Given this list of marker genes RB1, EGFR, IL6, ELK1, FAS, HSP90AA1, TRAF6, JUN, CCNE1, IL2, IFNG, FASLG, MAPK11 (mitogen-activated protein kinase 11), JUNB, HBEGF, FOS, MAP2K6, BCL2, ADAMTSL4-AS1, BCL3, NFE2L2, CDKN1A, BAK1, MAPK8, TNFSF10, CCNA2, TNFRSF1A, CFLAR, TP53, MMP2, TNF, BMF, MAP2K3, TRAF5, CCND1, MCL1, BCL2L11, BAX, ATF2, MAPK12 (NCBI Gene Id 6300), MAPK14, BCL2L1, MAP3K5, MAP2K4, PDGFRA, FGF7, BID, CDKN2A, MAPK13, MAP2K7, TRAF2, here is a description of the gene set: studied in species Homo sapiens Human Gene Set: WP_PHOTODYNAMIC_THERAPYINDUCED_AP1_SURVIVAL_SIGNALING Photodynamic therapy-induced AP-1 survival signaling